The following is a description of a gene set: studied in species Mus musculus electronically inferred by orthology from the curated human pathway part of: FGFR1 ligand binding and activation This event has been computationally inferred from an event that has been demonstrated in another species.<p>The inference is based on the homology mapping from PANTHER. Briefly, reactions for which all involved PhysicalEntities (in input, output and catalyst) have a mapped orthologue/paralogue (for complexes at least 75% of components must have a mapping) are inferred to the other species. Reactome Pathway: FGFR1c and Klotho ligand binding and activation, and this is the list of marker genes: Fgf23, Fgfr1, Kl (NCBI Gene Id 16591)